Given this list of marker genes Bcr, Rnaset2b, H2-D1, Lrrc8a, Jund, Rpl6, Polr3gl, Nherf2, Cfl1, Tmsb10, Drap1, Rpl13a, Sdhc, Eef1a1, Ube2g2, Snrpc (NCBI Gene Id 20630), Egfl7, Fth1 (NCBI Gene Id 14319), Bri3, Tmed9, Rhoc (NCBI Gene Id 99594), Eif4ebp1, Casp6, Cltb, Rbm26, Smagp, Map1lc3a, Zfp825, Mall, Lamtor1, P2ry12, Cox7a2l (NCBI Gene Id 20463), H3f3b, H2-Eb1, Cirbp, Tle5, Fbxo9, Ypel3, Oaz1, Tnfsf12, Cbfa2t3 (CBFA2/RUNX1 translocation partner 3), Ptpru, Spr, Anapc11, Maff, Ptms, Tomm6, Gnb1, Prrg2, Laptm4a, H2-Q6, Tmem160, here is a description of the gene set: species: Mus musculus from publication Tabula Muris Consortium (PMID 32669714) Mouse Gene Set: TABULA_MURIS_SENIS_HEART_ENDOCARDIAL_CELL_AGEING